Given this list of marker genes CRTAM, PVR, IL12B, CD160, CD226, NECTIN2, IL12A, here is a description of the gene set: Human Gene Set: GOBP_POSITIVE_REGULATION_OF_NATURAL_KILLER_CELL_MEDIATED_IMMUNE_RESPONSE_TO_TUMOR_CELL studied in species Homo sapiens Any process that activates or increases the frequency, rate, or extent of natural killer cell mediated immune response to a tumor cell.